Given this list of marker genes FHL2, RLIM, HMGB1, KCTD15, CTBP1, ID1, MECP2, HR, HIF1AN, PRKN, HDAC3 (histone deacetylase 3, NCBI Gene Id 8841), SIAH2, ANKRD1, KCTD1, SP100, PHF12, PFDN5, PARP10, TCERG1, GMNN, CIR1, ZNF451, AJUBA, RCOR2, SIN3B, CDY2B, ZMYND11, SRSF2, KDM5B, EID2B (EP300 interacting inhibitor of differentiation 2B), TBXT, SF1, SAP18, BEND6, NR0B1, RIOX2, IRF2BP2, EN2 (NCBI Gene Id 8311), TRIB3, SMARCA4, CDY1B, ENO1, NAB2, BASP1, HNRNPU, HMGA2, NCOR2 (nuclear receptor corepressor 2), ZFPM1, PA2G4, PARP14, CRYM, PAWR, HIPK2, BCL3, TLE6, ZMYND8, DMAP1, CTBP2, TSG101, DNAJB1, GPS2, TLE2, ID4, HDGF, PHF24, KMT5A (NCBI Gene Id 387893), CDYL, PRDM8, ATF7IP, SNW1, RUNX1T1, TBL1XR1, EID1, C1QBP, ATN1, CCAR1, KDM1A, DPF2, AASS, IRF2BP1, CIITA, ZNF366, TLE4, HDAC9 (NCBI Gene Id 9734), TCP10L, BCOR, MYBBP1A, CCND1, PPP1R13L, NIPBL, N4BP2L2, RUVBL2, ID3, CREBBP, NOC2L, MLIP, NPAT, MTA2, ZFPM2, TLE3, YAP1, FOXP3, MIER3, PIAS1, SIN3A, DNMT3B, MAD2L2, NCOA5, RCOR1, DDIT3, ASAH1, TDP2 (tyrosyl-DNA phosphodiesterase 2, NCBI Gene Id 51567), TRERF1, CDY1, TLE5, TBX6, SSX1, SETD5, C1D (C1D nuclear receptor corepressor), SPEN, SIRT6, TAF9B, HSPA1A, MAP3K10, LIMD1, CDY2A, TRIM22, SUFU, MIER1, HDAC1, MIDEAS, CREG1, SIRT1, SDR16C5, RB1, ARK2N, MTA3, EZH2, TOB2, TOB1, YEATS2, JAZF1, BTG2, NR0B2, TRIM28, NCOR1, URI1 (NCBI Gene Id 8725), TLE1 (TLE family member 1, transcriptional corepressor), SMAD7, CITED2, YAF2, FLYWCH1, HIRA, RBFOX2, UXT, EID2, MIER2, CDYL2, MED1, CHD4, ZNF354B, HSBP1L1, BCORL1 (NCBI Gene Id 93949), NSD1, DNMT3A, RCOR3, WTIP, DAXX, ZNF541, RBBP8, PIAS4, CNOT7 (CCR4-NOT transcription complex subunit 7), LMCD1, TBL1Y, PBXIP1 (PBX homeobox interacting protein 1), ID2, HDAC7, APEX1, HSBP1, WWTR1, PARP9, ELANE (NCBI Gene Id 6417), NRIP1, CASP8AP2, TLE7, CBFA2T2, SFMBT1, SMYD1, MTA1, TBL1X, SAP30, LCOR, SCAI, EZH1, EOMES, LMO4, ZNF653, FOXA2, BRD7, PEX14, PHB1, DDX54, RYBP, SFMBT2, PRMT5, CBFA2T3, CBX4, PARP15, RERE (arginine-glutamic acid dipeptide repeats), ARID5A, WNT4, COPS2, FOXH1, here is a description of the gene set: Human Gene Set: GOMF_TRANSCRIPTION_COREPRESSOR_ACTIVITY species: Homo sapiens A transcription coregulator activity that represses or decreases the transcription of specific gene sets via binding to a DNA-binding transcription factor at a specific genomic locus, either on its own or as part of a complex. Corepressors often act by altering chromatin structure and modifications. For example, one class of transcription corepressors modifies chromatin structure through covalent modification of histones. A second class remodels the conformation of chromatin in an ATP-dependent fashion. A third class modulates interactions of DNA-bound DNA-binding transcription factors with other transcription coregulators.